The following is a description of a gene set: Mouse Gene Set: TABULA_MURIS_SENIS_MAMMARY_GLAND_B_CELL_AGEING from publication Tabula Muris Consortium (PMID 32669714) species: Mus musculus, and this is the list of marker genes: Prdx5, Ndufs6, Krtcap2, Spint2, Ctsb, Ptprc, Calm1, Sec11c, Fkbp2, Taldo1, Tnrc6b, Vim, Ucp2, Vamp8, Tmed3, Zfp36l1, Dcn, Cd44, Bloc1s1, Txndc5, Rac2, Lamtor2, Pdia4, Rap1a, Emc10, Hnrnpm, Mettl23, Lmna, Unc93b1, Snf8, Bcl11a, Cyp4f18, D8Ertd738e, Ddost, Mt2, Tcf4, Ifi30, Vars1, Cd81, Grb2, Dbnl, Csrnp1, Capg, Ly86, Bcl2, Gpr183, Gnas, Pdcd4, Cuta, Macroh2a1, Fxyd5, Cnp, Cox6c, Gm2a, Ptp4a2, Tnfaip6, Coro1a, Atp5me, Rnf187, Gpsm3 (NCBI Gene Id 106512), Erp44, BC004004, Sec61b, Myl12a, Sik1, Ahnak, Spcs2, Atp5pd, Klf4, Aldh2, Mt1, Fermt3, Itm2c, H2-D1, Ndufa1, Ssu72, H2-Oa, Crlf2, Rrbp1, 4930523C07Rik, Arpc2, Arpc5l, Clic4, Scand1, Sh3bgrl3, Sp140l2, Ppp3ca, Cybb, Anxa5, Tmem243 (transmembrane protein 243, mitochondrial), Igfbp6, Xbp1, Ndufa13, Smdt1, Cmpk1, Sqstm1 (NCBI Gene Id 18412), Sdf2l1, Slpi, Mtarc2, Ergic3, Atox1, Ppp1ca, Napsa, Ptprcap, Ctsa, Creld2, Ikzf1, Cd52, Bhlhe40, Calm3, Cfl1, Rgcc, Hsp90b1, Actg1, Ndufs8, Pycard, Psmb10, Vmp1, Lgals1 (lectin, galactose binding, soluble 1), Ostf1, Fam43a, Actb, Ssr3, Ptpn6, Sdhb, Pdia3, Lsp1, Tnfaip3, Txn1, Ndufa4 (NCBI Gene Id 17992), Sp140l1, Cd72, Ptms, Nfatc1, Hspa5, Psmb9, Grcc10, Tmem256, Psmb8, Rbm3, Smim14, Odc1, S100a13, Psap, Chtop, Tnfaip8, Gnai2, Cyb561a3, Selenok, Ddrgk1, Rexo2, Ndufa7, Gng10, Ndufs7, Sp140, Ctsh, Ralgps2, H2-T23, Anapc13, Pitpna, Tm9sf3, Siah2, Pafah1b3, Rhob, Cyba, Syk, Tmem134, Lcp1, Tmem160, Vps25, Slfnlnc, Tln1, AW112010, Pet100, Comt, Anxa6, Spcs1, Ndufa11, Mzb1, Ndufa2, S100a6, Pfn1, Tle5, Derl1, Man1a, Herpud1, Hnrnpa2b1, Cetn2, Id2, Prdx2, Klf13, Acp5, Celf2, Gpx3, Npc2, Edem1, Fosb, Cotl1, Kctd12, Oaz1 (ornithine decarboxylase antizyme 1), Tsc22d3, Pld4 (phospholipase D family member 4), Tecr, Ptpn18, Gsn, Anapc5, Gimap3, Gimap4, Romo1, Actr3, Mrpl52, Swi5, Dnajc7, Cyb5a, Cirbp, Cd38, Ms4a1, Hvcn1, Gimap6, Tmem258, Ly6a, Tspo, Gpx1, H13, Cd47, Cd79a, H2-K1, Cnn2, Cd79b, H2-DMb1, H2ac18, Crip1, Ctss, Gltp, Klf2, Atp5pf, Dok3, Cst3, H3f3b, H1f2, 1810037I17Rik, Bbln, Evi2a, Cdc42se2, Etfb (electron transferring flavoprotein, beta polypeptide), Selenow, Jchain, Dnajc3, Calm2, Dpm3, Fus, Jund, Tram1, Ncf4, Nrm, Cd22, Rnase6, Cdk2ap2, Cenpx, Itm2b, Ube2r2, Park7, Ccl5, B2m, Ssr4, Cope, Krt14, Rpn2, Evl, Slc25a4, Pkm, H2az2, Ddx3x, Mdh1, Mrpl33, Pmf1, Myl12b, Dbi, Gpr18, Selenos, Egr1, Cox6b1, Elob, Ppib, Myl6, Ndufa3, Csk, Lbh, Atp5mg, Arhgdib, Rps28, Sec61g, Ly6d, Vps28, Ltb, Atf3, P4hb, Manf